Given this list of marker genes Adam10, Tnik (TRAF2 and NCK interacting kinase), Tmem108 (NCBI Gene Id 81907), Ghsr, Hras, Kalrn, Dag1, Gpc6, Gpc4, Rapgef4 (NCBI Gene Id 71744), Iqsec2 (IQ motif and Sec7 domain 2), Nbea, Vps26b, Kif2c, Map2k1, Prkcz, Cacna2d2, Camk2a, Gabarap (gamma-aminobutyric acid receptor associated protein), Magi2, Neto2, Gsk3b, Traf6, Rap1a, Ogt, here is a description of the gene set: Mouse Gene Set: GOBP_REGULATION_OF_NEUROTRANSMITTER_RECEPTOR_LOCALIZATION_TO_POSTSYNAPTIC_SPECIALIZATION_MEMBRANE studied in species Mus musculus Any process that modulates the frequency, rate or extent of neurotransmitter receptor localization to postsynaptic specialization membrane.